The following is a description of a gene set: studied in species Homo sapiens Human Gene Set: ACATTCC_MIR1_MIR206 Genes having at least one occurence of the motif ACATTCC in their 3' untranslated region. The motif represents putative target (that is, seed match) of human mature miRNAs hsa-miR-1 and hsa-miR-206 (v7.1 miRBase)., and this is the list of marker genes: AZIN1, DHX15, CAAP1, FBXO33, MAP4K3, STC2, VEGFA, GRK6, WDR48, PHAX, MAB21L1, CNN3, USP33, C1GALT1, TMSB4XP8, PTPRG, GAS2L1 (NCBI Gene Id 10634), TMEM243, KDM2B (NCBI Gene Id 84678), POLDIP3, MNT, EDN1, DDX17, TMOD2, ANKRD29, WIPF2, EYA4, BSDC1, DGKZ, PIAS3, ZNF580, TBC1D15, JUND, CELSR3, MAPKBP1, MTCL2, MON2, HNRNPU, POLA1, SNX2, AP3D1, HNRNPK (NCBI Gene Id 3190), ATP6V1A, AKAP11, ZIC4, EIF4E, BET1, SEC22B, GDAP1L1 (ganglioside induced differentiation associated protein 1 like 1), TRA2B, DDX5, SEMA6D, MFSD14A, MAP1A, ZFP36L1, SETBP1, FAM91A1, TNPO2, WBP1L, TSPAN4, EFNB2 (ephrin B2), ZBTB6, SP2, CEBPZ, FNDC3A, PHF6, ACACA (acetyl-CoA carboxylase alpha), NCK2, NEXMIF, ZNF280D, JOSD1, VAMP2, KHSRP, KCTD13, E2F5, PAX3, FRAS1, PUM2, MEX3C, ADAR, HS3ST3B1, FZD7, MAL2, SMARCB1, BAG4, RNF38, MEOX2, RNF13, DNAJC5, POGK, SLC25A22, CITED2, ZBTB4, IP6K2, SYNJ2, RIT2, HMGCR, NRP1, RCAN2, EIF1AX, CTTNBP2NL, KANK4, RNGTT, ARID2 (NCBI Gene Id 57676), BCL7A, BSCL2, LIN7C, HOXB4, TBP, TNKS2, SRSF3, SULF1, SLC7A2, AKAP12, SRGAP2, UBN1, BSN, G6PD, NCOA3, UST, RARB, CDK6, ZNF827, NUP50 (nucleoporin 50), FN1, UBQLN1, PBRM1, CPED1, TPM3, CYB5B, SMARCA4, RSBN1, TRIM2, FOXP1, TKT, SLC44A1, EAF1, COL4A3, TGIF2, AMMECR1L, TIMP3, CPLX2, SLC8A2, SLC38A3, SRSF9, ANXA4 (annexin A4), KIF2A, ACAP2, RSBN1L, ARHGEF18, OLFML2A, PIP4P1, ANP32B, SEC63, OSBPL7 (oxysterol binding protein like 7), PREX1, UBE4A, OTX2, AGO1, ARK2C, DMPK, ETS1 (NCBI Gene Id 2113), NADK, KLF13, OGT, GIT1, GNPDA2, TSPYL4, MATR3, RRBP1, SMIM14, NGFR, MET (NCBI Gene Id 4233), MSANTD2, CREM, ATP7A, GDF6, ADGRA3, TMCC1 (NCBI Gene Id 23023), SNAP25, ANXA2, CLCN3, C2orf69, FBXW7, SPRED1, RASA1, DAAM1, CLTC, PDLIM5, SLC7A6, PICALM, MYO1E, WDR6, SKIC8, SMAP1, CREBL2, ZNF236, NAP1L5, CREB5, DGKG, PAFAH1B1, BLCAP, NR1H3, TMEM178A (NCBI Gene Id 130733), PHLPP2, SFRP1, FOSB, FNDC3B, SLC37A3, ZNF800, ARRDC3, MIPOL1 (mirror-image polydactyly 1), SLC35F1, ATG14, SS18, PDIK1L, TGFBR3, BCLAF3, HSPD1, HIVEP2, VAMP4 (vesicle associated membrane protein 4), CDK14, DCAF12L1, PLPPR4, UBR5, KTN1, DNAJC13, ATG13, NR4A2, CDC42, PHC2, ARCN1, GJA1, RSPO3, LRRC8A, HIC2, YWHAZ, SMYD4, SLC39A10, NCL, SEC62, CCDC141, SLC25A25, MMD, RNF138, PPP4R3B, BICD1, CPSF7, DLG4, CDK9, QKI, GPD2, TRAPPC3, BDNF, MRTFA, RIMS4, TSPAN9, ZNF146, VEZF1, PSD3, YWHAQ, STARD7, CPEB1, HACD3, MEIS1, KCNIP3, HELZ2, NOL4L, SRSF1, RICTOR, GCH1, ELOF1, TPPP, HSP90B1, ARF3, TTC7B, TFEC, CORO1C, FGF14, TAGLN2, YPEL2, ADPGK, TWF1, RNF145, IGF1, ABCB7, AP1G1, SH3BGRL3, BPNT1, ZMAT3, PDCD10, MED1, MYLK, HMGN1, PPIB (NCBI Gene Id 5479), RIMOC1, HDAC4, VGLL4, UBE2H, BACH2, CBL